Given this list of marker genes TPM1, ADRB1, DRD5, ADRA1A, ADRB2, ADRB3, here is a description of the gene set: studied in species Homo sapiens Human Gene Set: GOBP_REGULATION_OF_SYSTEMIC_ARTERIAL_BLOOD_PRESSURE_BY_NOREPINEPHRINE_EPINEPHRINE The process in which the secretion of norepinephrine or epinephrine into the bloodstream modulates the force with which blood passes through the circulatory system.